The following is a description of a gene set: Human Gene Set: MODULE_236 species: Homo sapiens Genes in the cancer module 236., and this is the list of marker genes: VLDLR, APOA1, LDLR, LRP8, SOAT2, NR0B2, STARD3, SCARB1, MBTPS2, APOL1, NMT1, APOE, UGCG, CETP, SREBF1, CELA3A, SORL1, APOB (NCBI Gene Id 338)